Given this list of marker genes Vav1, Akt2, Rac1, Vav3, Prr5, Vav2, Nos3, Mlst8, Ctnna1, Calm3, Pak3, Trib3, Mtor, Calm2, Pak1, Cav1, Mapkap1, Jup, Hsp90aa1, Cdh5, Calm1, Pak2, Pdpk1, Akt3, Rictor, Ctnnd1, Them4, Ctnnb1, Akt1, here is a description of the gene set: VEGFR2 mediated vascular permeability studied in species Mus musculus Mouse Gene Set: REACTOME_VEGFR2_MEDIATED_VASCULAR_PERMEABILITY